The following is a description of a gene set: Spastic weakness affecting all four limbs. studied in species Homo sapiens Spastic tetraparesis Human Gene Set: HP_SPASTIC_TETRAPARESIS, and this is the list of marker genes: STAMBP, SOD1 (superoxide dismutase 1), SDHD, ATP5F1A, SNAPC4, AASS, TMEM222, FA2H, TNR, RNU7-1, GM2A, ATP6V1A, LIPT2, FBLN1, PRPS1, EARS2, HSD17B10, DYM, LIPT1, PRUNE1, AFF3, EIF2S3, KCNJ6, ALG3, PSAP, PHACTR1, RERE, ALS2, SMC1A, GUF1, TACO1, EXOSC8, ESAM, NUP62, STXBP1, EIF4A2 (NCBI Gene Id 63124), L2HGDH, TRAPPC4, MFSD2A, PLP1, SDHA, TBCE, AUH, PAFAH1B1, REEP1, SDHB (NCBI Gene Id 96200), SLC18A2, SOX4, LMNB1, LYRM7, MT-ATP6, PLA2G6, ARX, SLC35A2, PRDM8, PSAT1, NFU1, IFIH1, WDR62, LMX1B, MOCS1, MRAP, SDHAF1, PSEN1, ABCD1, KCNQ2, MRM2, FAR1, GSS, COA8, ADAR, APOE, AHDC1, NUP54, ERLIN2